Given this list of marker genes PIK3R2, STAT5B, LYN, GRB2, PIK3CA, STAT3, PIK3R1, LCK, FYN, HRAS, STAT1, PIK3R3, SRC, NRAS, YES1, KRAS, JAK2, KIT, STAT5A, SOS1, here is a description of the gene set: studied in species Homo sapiens Signaling by KIT in disease Human Gene Set: REACTOME_SIGNALING_BY_KIT_IN_DISEASE